Given this list of marker genes Epha4, Efna3, Ager, Lyn, Efna1, here is a description of the gene set: studied in species Mus musculus Mouse Gene Set: GOBP_POSITIVE_REGULATION_OF_ASPARTIC_TYPE_ENDOPEPTIDASE_ACTIVITY_INVOLVED_IN_AMYLOID_PRECURSOR_PROTEIN_CATABOLIC_PROCESS Any process that activates or increases the frequency, rate or extent of aspartic-type endopeptidase activity involved in amyloid precursor protein catabolic process.